The following is a description of a gene set: Human Gene Set: GSE14415_INDUCED_TREG_VS_FOXP3_KO_INDUCED_TREG_IL2_CULTURE_UP The gene expression profile of peripheral Foxp3+ natural regulatory T cells isolated from Foxp3/EGFP bicistronic mice was compared to that of in vitro-induced regulatory T cells and to CD4+ conventional (Foxp3-) T cells. The role of the regulatory T cell transcription factor Foxp3 in shaping the transcriptosomes of natural and induced regulatory T cells was analyzed using mice expressing a mutant FOXP3-EGFP fusion protein (Foxp3deltaEGFP). We used gene expression microarrays to examine the transcriptional programs of natural and induced regulatory T cells and the function of Foxp3 in organizing the transcriptosomes of the respective cell type from publication Haribhai D, Lin W, Edwards B, Ziegelbauer J, Salzman NH, Carlson MR, Li SH, Simpson PM, Chatila TA, Williams CB (PMID 19265124) species: Homo sapiens Genes up-regulated in induced T reg cultured with IL2: wildtype versus non-functional FOXP3., and this is the list of marker genes: RNF2, PPBP (NCBI Gene Id 90374), KLRC2, GPX8, TREM1, IER3, GABARAPL1, PTTG1, ZFYVE16, CMKLR1, GLCCI1, SAR1A, GOLIM4 (NCBI Gene Id 27333), GIMAP7, SETBP1, C1orf54, GEM, TMF1, GCH1, PDE4D, PHF11 (NCBI Gene Id 51131), PPM1J, SLC15A3, ALCAM, IL10RA, TSPAN2, BAG1, GPR160, CXCL10, PILRA, HTATIP2, CCDC88A, GGH, CCL4, HOPX, ANLN, GALNT3, ODC1, IFIT1, MXD1, NELFE, UIMC1, TNFSF4, NRARP, CIDEB, SV2C, SCLT1, HERC5, RGS16, ITGA1, SNX18, SAP30, CHSY1, CHPT1, RORA, AIM2, MICAL1, CXCR6, PRF1, CRELD2, ADGRG1, NKG7, COQ10B, PSMD14, NR2F6, H2BC4, GXYLT1, SYPL1, BST1, LAG3, MX1, KIF14, FGL2, MPHOSPH6, GRB7 (growth factor receptor bound protein 7), LYRM1, PGLYRP1, CIBAR1, CD38, H1-2, PLA2G7, MYL4, IL1B, RBM47, ELL2, AK3, OCIAD2, CREM, SMNDC1, ETAA1, EHD4, CXCR3, CHST11, NFKBIA, MLKL, SNX10, AIF1, XCL1, NCALD, TMEM163, EZH2, ANXA4, CEACAM1, ACADL, MYADM, PRDM1, TRPS1, TTC39B, MPEG1, IFIH1 (interferon induced with helicase C domain 1), NAB1, ICOS, EMC3, IFI16, EEA1, KCNIP3, NR4A2, RILPL2, CYSLTR2, TXNDC17 (NCBI Gene Id 84817), ID2, SUB1, PLSCR1, SERPINI1, HSPA4L, PNP, PANX1, RGS1, ARMCX5, RFK, ITIH5 (NCBI Gene Id 84903), LAMTOR3, ZFP69, MYBL1, ARAP2, AREG, ERCC6L, CARHSP1, CENPQ, ISG20, ST8SIA4, ZEB2, APOBEC2, LRATD1, SH3GLB1, SLK, BEX3, H1-0, XYLT1, TCEAL9, RAP2A, CLEC4D, INSL6, SAMD3, EOMES, PMAIP1, PGM2L1, MTPN, FCGR2B, COBLL1, NIBAN1, DDX28, ITGB1, CX3CR1, IL18RAP, S100A11, ITGAM, SOCS6, RTP4, PON2, CLGN, SRGN, TRIP11, F2R